The following is a description of a gene set: species: Homo sapiens Human Gene Set: HP_NEOPLASM_OF_THE_HEART Neoplasm of the heart A tumor (abnormal growth of tissue) of the heart., and this is the list of marker genes: IFNG, PTCH2, MYH11, KCTD1, TSC1, TSC2, ACTG2, MYH8, LMOD1, PRKAR1A, PTCH1, SOX6, SUFU, PDE11A, MYLK